The following is a description of a gene set: Any process that stops, prevents or reduces the frequency, rate or extent of an inflammasome-mediated signaling pathway. species: Homo sapiens Human Gene Set: GOBP_NEGATIVE_REGULATION_OF_INFLAMMASOME_MEDIATED_SIGNALING_PATHWAY, and this is the list of marker genes: PYDC2, MEFV, IFI16, ABHD17A, NLRP2B, HSPA8, TRIM65, OGT, TRIM11, CARD8, FBXL2, CPTP, NLRC3, TREM2, IRGM, PYDC1, ABHD8, TRIM31, ZDHHC12, PYDC5, LAMP2, CSNK1A1, SIRT2